Given this list of marker genes GDF5, HNRNPR, CHSY1, BMP2, BMPR1B, here is a description of the gene set: Deviation of the 2nd toe species: Homo sapiens Human Gene Set: HP_DEVIATION_OF_THE_2ND_TOE